Given this list of marker genes Rspo2, Pcsk6, Zic3, Lmo2 (NCBI Gene Id 16909), Asb4, Wnt3a, Wls, Wnt9a, Rspo1, Wnt2b, Wnt5a, Fzd10, Spry1, Wnt8b, here is a description of the gene set: from publication Bedogni F, Hevner RF (PMID 34321999) Mouse Gene Set: HEVNER_CORTEX_CORTICAL_HEM Genes expressed by cells in the cortical hem patterning center of embryonic day 14.5 mouse cortex. species: Mus musculus